The following is a description of a gene set: Human Gene Set: MIR548AD_5P_MIR548AE_5P_MIR548AY_5P_MIR548B_5P_MIR548D_5P studied in species Homo sapiens from publication Chen Y, Wang X (PMID 31504780) Genes predicted to be targets of miRBase v22 microRNA hsa-miR-548ad-5p, hsa-miR-548ae-5p, hsa-miR-548ay-5p, hsa-miR-548b-5p, hsa-miR-548d-5p in miRDB v6.0 with MirTarget v4 prediction scores > 80 (high confidence targets)., and this is the list of marker genes: WDR7, S1PR1, CCNG2, TMEM65, SF3A1, DEFA6, LSAMP, TMED7, ARID2, ERC2, MFSD8, ACBD5, AIDA, SIX4, MTF1, NAV2, GPATCH11, CBX3 (NCBI Gene Id 82756), GRID2, ARRDC4, STEAP2, EPB41L5, EDIL3, NOTUM, LPP, REV3L, PAX5, EXOC5, SMAD5, RGPD4, SREK1, TFDP3, TMEM135, FAM199X, SCARF1, TRUB1, ALG11, BTG3, SKIDA1, RHPN2, MAGT1, PPHLN1, CACNA2D3, PRKG1 (NCBI Gene Id 5592), ZNF559, LACTB, AGTR1, PITX2, AHSA2P, RNF149, B3GALT5, NAT1, SRP9, LIN7A, ANGEL2, ADAMTS1, NOTCH2, CCDC179, PGAM1, PRELID2, TP53INP1, CD99, SACS, BEND7, SPAG9, RFC3, ZNG1F, CDK6, NCKAP1, CCP110, U2SURP, RHOQ, ZNG1C, MBNL3, SLAIN1, PRPF39, SYTL5, NAA30, ZC3HAV1L, DPY19L3, ADAM22, MINDY2, TRPC5, GASK1A, NRXN1, CSGALNACT2, PRRC1, LANCL1, DNAJB4, HIPK1, ACVR2B, FOXG1, LACTB2, ZEB2, MMUT, GUCY1A2, PROSER1, RIMOC1, ZDHHC2, FLRT3, HOXD13, BBS10, TIFAB, UTP3, PTPRG, SFMBT1, FGL2, PRKAA2, GPC6, GRM5, CCNY, DCDC2, ZBTB20, SNX30, ZNF503, PREX2, TNFRSF21, BBX, MBNL2, GOPC, TBCA, DUSP7, MED6, RALA, SEC24A, ZBTB41, ZNF652, STXBP5, ARK2N, POLR2H, ZNF792, ARFRP1, CHST9, C21orf91, MIER3, IKBIP, ZCCHC8, ANKRD26, KLF8, LRRC4B, FGFR1OP2, NFKB1, ACBD3, RAP2A, ZBTB11, ZFAND5, BMI1, SENP1, RORA, RFX7, ARL13B (ADP ribosylation factor like GTPase 13B), SNAP91, GCC2, OAZ1, RPS6KA5, DENND1B, CEP120, COMMD3-BMI1, TRIM2, BTF3L4, SPOCK3, KPNA4, AK3, DOLPP1, ACTN4, CFDP1, CRACD, FBXL3, CEP350, MTA1 (metastasis associated 1), GRIP1, FNIP2, GPD2, SCAMP1, NUP54, CAPN2, GRM7, DIAPH3, PPP5C, CERS6, MCF2L2, UGT8, LMX1A, FAM135A, NUP160, ZNF608, CNTN1, ZDHHC21, ARMCX3, ZNF148, PPARG, KRT28, SRSF6, YIPF5, PTGFRN, ADAMDEC1 (NCBI Gene Id 27299), XPNPEP1, TMEM200A, CRIPT, KIF20B, MIER1, ADAM30, RNF138, GABRA4, C5orf24, CACUL1, CCSER1, MTMR6, UGDH, LRRTM3, MEX3D, GPR85, SPATA6L, PPP1R9A, LRRC7, GSE1, C11orf87, BTG2, CA8, RASSF8 (NCBI Gene Id 11228), ADH5, TXLNG, CCDC117, ANKRD10, ITGAV, C6orf120, TPM3, LMCD1, SDC2, CAMSAP2, BOD1L1, LRP1B (NCBI Gene Id 55424), POU2F1 (POU class 2 homeobox 1), PLEKHG1, BRWD1, AFTPH, HOOK3, SCN8A, SNX16, PIWIL3, MMP16, ZNF492, RICTOR, TLCD4, RMND5A, NUMB, MAST3, NTF3, KLF7, CLCN4, NDFIP2, EEA1, HOMER1, RGPD5, FEM1C, SESTD1, SCN3A, GABPA, MFN1, AQP3, FYB2, IGF2BP3, NDC1, RIC1, SCN1A, ONECUT2, NOS2, MZT1, SFT2D1, WDR47, ABI3BP, SETD2, FAM221A, UBA6, PPEF2, CCDC50, SLC30A5, RGPD8, GULP1, SEC22C, DAAM1, OGFRL1, ZBTB10, LARP4, HNRNPDL, SAMD8, LCTL (NCBI Gene Id 197021, lactase like), CHRNA7, ZNF486, SERINC3, CCDC47, PRPF40A, ZBTB25, DHRS1, MIDEAS, DYNC1LI2, CAMLG, PSMC2, MEIS2, HLTF, A1CF, DTWD2, ITGB6, HDAC9, PROK2, CBFB, PHYHIPL, CD163, FNDC3B, IGSF3, CCNB1, EPHA3, C3orf38, FMNL2, AP1AR, ZNG1B, IGF1, SRSF3, MECP2, RESF1, PAQR9, RETREG1, ASB3, PLEKHH2, SOX5, RO60, FZD3, TMEM167B, GNAQ, PPP1R2, PRKAG2 (NCBI Gene Id 7981), FRMD5, SLC4A7, ELL2, WDR26, KIAA1586, CHN1, ZNF680, SERINC5, RAP1A, MDFIC, RC3H1, RGPD6, WAPL, GTF3C3, SSR3, ARL6IP6, SPDYE1, NRG4, GCNT1, THSD7A, PRKAA1, SANBR, ZNG1E, BRWD3, UNC80, MGARP, METTL8, GLIPR1, TMEFF2, PTBP3, TRPC1, ATP11A (NCBI Gene Id 84170), GSTCD, MAP9, TMTC3, UBE2A, NEDD4L, ETF1, ANAPC1, SYNM (synemin), RAB8B, PAPOLG, MYCN, RAB27B, CMPK2, ZNF454, MTFR1, JARID2, FZD7, CSNK1D, TFAM, SDE2, ZNF747, ATXN2, DDIT4, DIP2B, CFL2, GPR155, TMEM255A, LCOR, TCF12, ZNG1A, SUMF1, PDZRN4, ADGRB3, PDCD5, RBBP8, HECA, SLC24A3, TMTC1, KLF10, GAPVD1, ACAT2, SECISBP2L (SECIS binding protein 2 like), MAML1, KCNJ3, CISD2, DYNC1I2, RRAGD, EIF2AK2, NFAT5, PCLO, GABPB1, HMBOX1, NR2C1, ZDHHC15, ANKRD22, PRP4K, ZNF326, RNF217, CIAO2A, FIGN, NUP50, FAM133A, ME1, GUCY1B1, MBIP, TTC13, CYBRD1, ZBTB44, ANKRD46, ACADL, CTNNA3, KLRD1, TRA2B, TRAM1 (translocation associated membrane protein 1), PGRMC2, C9orf40, PCDH11X, MAST4, FGD4, ABCA5, GATM, SCML2, KATNBL1, CARF, KL, EVI2A, SH3D19, CLDN12, MPHOSPH8, PCDH11Y, METTL6, MARCHF6, SAMTOR, BCL2L2, CLVS2 (NCBI Gene Id 387358), APPBP2, TTC19, SDF4, PTPRR, PDE4D, AFDN, FZD5, STYX, MAP4K4, COL11A1, LVRN, TBCK, PPP1R27, GOLGA6L2, GPALPP1, TRIM9, NEGR1, BNIP3, DUS4L, MIGA1, PDE1C, URI1 (NCBI Gene Id 8725), LATS1, RGS7BP, DNAJB14, SMAD9, CFAP44, TOLLIP, ATXN7L1, UEVLD, IKZF2, MMD, FSBP, ZRANB2, SLU7, HTR2C, SMG1, SLCO5A1, ODAPH